Given this list of marker genes ZEB2, PDCD6IP, FGFR3, KDM1A, HRAS, PTEN, BICRA, here is a description of the gene set: Enlarged cerebellum An abnormally increased size of the cerebellum compared to other brain structures. Human Gene Set: HP_ENLARGED_CEREBELLUM species: Homo sapiens